The following is a description of a gene set: Human Gene Set: HP_BROAD_ALVEOLAR_RIDGES Broad alveolar ridges studied in species Homo sapiens, and this is the list of marker genes: ARX, DIS3L2, SH3PXD2B, ZC4H2, FIG4, GNS, RERE, GJA1, OFD1, DHCR7, VAC14, ATP6V1B2, SETBP1 (NCBI Gene Id 284262), TBC1D24, ASXL1